The following is a description of a gene set: Any process that results in a change in state or activity of a cell (in terms of movement, secretion, enzyme production, gene expression, etc.) as a result of a vitamin stimulus. Mouse Gene Set: GOBP_CELLULAR_RESPONSE_TO_VITAMIN species: Mus musculus, and this is the list of marker genes: Penk, Folr1, Mn1, Vdr, Fgf23, Kank2, Snw1, Fes, Gas6, Folr2, Rxra, Gdap1, Col1a1, Mdm2, Lep, Cyp27b1, Postn, Gprin3, Phex, Kdm6a, Pdia3, Casr, Sfrp1, Trim24, Med1, Snai2, Pim1, Cyp24a1, Tnc, Brip1, Rxrb